Given this list of marker genes ADAMTS14, TUBB, NR3C1, USP25, CCDC77, PNKD, here is a description of the gene set: from publication Chen Y, Wang X (PMID 31504780) Genes predicted to be targets of miRBase v22 microRNA hsa-miR-339-3p in miRDB v6.0 with MirTarget v4 prediction scores > 80 (high confidence targets). species: Homo sapiens Human Gene Set: MIR339_3P